The following is a description of a gene set: This event has been computationally inferred from an event that has been demonstrated in another species.<p>The inference is based on the homology mapping from PANTHER. Briefly, reactions for which all involved PhysicalEntities (in input, output and catalyst) have a mapped orthologue/paralogue (for complexes at least 75% of components must have a mapping) are inferred to the other species. Reactome Pathway: Chylomicron assembly electronically inferred by orthology from the curated human pathway species: Mus musculus part of: Plasma lipoprotein assembly, and this is the list of marker genes: Apoa4, Apoe, Apoa2, Apob, Apoc3, Apoa1, P4hb, Apoc2